Given this list of marker genes RPL36A, RPLP2, RPS26, EIF3J, RPL7, RPL37, EIF3I, EIF3C (eukaryotic translation initiation factor 3 subunit C), RPL7A (NCBI Gene Id 6130), FAU, RPL27A, EIF3L, EIF2B4, RPL27, RPS10, RPS20, EIF4B, EIF3F, EIF4E, RPL6, RPL12, RPS18, RPLP0, RPL24, RPS21, EIF2B1 (NCBI Gene Id 1967), EIF2S1, RPL41, RPL29, EIF2B2, RPL5, EIF3A, RPS3A, EIF4EBP1, RPL4, RPS2, RPL3, EIF1AX, RPS16, EIF3E, EIF2B3, RPL22, PABPC1, RPS4Y1, RPL35, RPS12, RPL37A, EIF3G, EIF3H, RPL39L, RPS8, EIF2B5, EIF4H, UBA52 (NCBI Gene Id 7311), EIF3M, RPL15, RPS4Y2, RPL11, EIF3K, RPS27L, RPS4X, RPL8, RPL9, RPS28, EIF2S2 (NCBI Gene Id 9359), RPS27A, RPS25, RPL34, RPS24, RPL36AL, RPL22L1, RPL10A, RPS19, RPS29, RPL23, EIF2S3, EIF3D, RPL10, RPSA, EIF5, RPL28 (NCBI Gene Id 6158), RPL35A, RPL17, RPS15A, RPL36, RPL26, RPS15, RPS5, RPS17, RPS11, EIF4G1, RPL14, RPLP1 (ribosomal protein lateral stalk subunit P1), RPL38, RPL26L1, RPL39, RPL13A, RPL3L, EIF4A1, EIF4A2, RPL10L, RPL19, RPL30, RPL18, RPL23A, RPS3, RPS13, EIF5B, RPS14, RPS23, RPS6, RPL31, RPL32, RPL13, RPS7, RPL18A, EIF3B, RPS9, RPS27, RPL21, here is a description of the gene set: Eukaryotic Translation Initiation Human Gene Set: REACTOME_EUKARYOTIC_TRANSLATION_INITIATION species: Homo sapiens